Given this list of marker genes Ppp1r1c (NCBI Gene Id 75935), Adipor1, Prpf3, Cntn5, Psme3, Timp3, Tox, Pafah2, Neurod4, Mtf1 (NCBI Gene Id 17764), Dtna, Krtap31-1, Tafa1 (NCBI Gene Id 320265), Gstm6, Cyp2c23, Cavin2, Fhit, Lepr, Gtf3c2, Sv2b, Glg1, Clasp2, Fbxo28, Gkn2, Smc3 (structural maintenance of chromosomes 3), Col6a5 (collagen, type VI, alpha 5), Zfp94, Hspa13, Phyhipl, Rusc1, Bmp2, Fam53c, Il20ra, Kcng3, Kpna6, Ralgapa1, Dctn6, Bcap29, Scp2, Ccdc71l, Cps1 (NCBI Gene Id 28143), Cxcl10, Ppm1f, Bbs9, Daam2, Gjc3, Ctdsp2 (NCBI Gene Id 52468), H2-M10.5, 4931406C07Rik, Neu3, Foxn2 (forkhead box N2), Acadm, Srcin1, Dhrs9, Mtcl2, Chd3, Grm5, Lyve1, Cnr2, Serpinf2, Tyrp1, Gcnt1, Sptlc3, Atp1b2, Cd38, Sptan1, Gpr173, Krt33a, Apol7c, Psg25, Psen1, Pdgfra, Dnajc11, Snd1, Rd3, Rfk, Grid1, Cdh4, Zmat2, Gata6, Xaf1, Scara3, Aamp, Kcnk18, Agrn, Zim1 (zinc finger, imprinted 1), Tmem8b, Mmp20, Slc25a23, Kcnq5, Rabl2, Galnt9, Elf2 (NCBI Gene Id 99951), Exoc8, Prokr2, Nras, Pag1, Rab1b, Zmynd11, Commd8, Cybrd1, Srl, Fgfr2, Slc16a5, Ywhaq, Cd99l2, Eda2r, Rhobtb1, Scrt1, Minar2, Apol7a, Zfp410, Pitpna, Ablim1, Nfia, Larp1, Exosc9, Tmem184b, here is a description of the gene set: studied in species Mus musculus Genes predicted to be targets of miRBase v22 microRNA mmu_miR_3547_5p in miRDB v6.0 with MirTarget v4 prediction scores > 80 (high confidence targets). Mouse Gene Set: MIR_3547_5P from publication Chen Y, Wang X (PMID 31504780)